Given this list of marker genes Tamm41, Nr1h4, Mvd, Pigc, Isyna1, Adgrf5, Inpp1, Itpkb, Pdgfb, Dpm3, Pip5kl1 (NCBI Gene Id 227733), Cds1, Smg1, Dhrs7b, Acsl5, Pigm, Chpt1, Chkb, Pik3c2b, Slc27a1, Ppard, Pigh, Pcx, Hycc2, Dgkk (NCBI Gene Id 331374), Sgms1, Piga, Inppl1, Pik3cd, Tafazzin (NCBI Gene Id 78810), Uvrag, Lpcat2b, Lpgat1, Fitm2, Agpat3, Pik3ca, Pigz, Atm, Pip4k2a, Ptprq, Hmgcs2, Pip4k2b, Pigf, Abhd5, Sptlc1 (serine palmitoyltransferase, long chain base subunit 1), Ttc7, Agpat2, Fdps, Htr2a, Dgkh, Cept1, Cwh43, Lpcat4, Lpcat3, Lclat1, Hexb, Lpcat1, Dpm1, Pi4ka, Far1, Pi4k2b, Etnk1, Pgap1 (NCBI Gene Id 75976), Abca8b, Cds2, Pign, Pld1 (phospholipase D1), Pip5k1c, Lcat, Pla2g5, Ormdl1, Fabp5, Sphk2, Pisd, Idi1, Gpaa1, Ptdss2, Pigb, Inpp4a, Pigw, Vapa, Pla2g6, Sh3yl1, Rab38, Fitm1, Pik3cb, Pgap3, Pigv, Samd8, Pigq, Dolk, Bpnt2, Sgms2, Itpkc, Gpat4, Hycc1, Flvcr1, Pip5k1a, Mppe1, Chka, Ptdss1 (NCBI Gene Id 19210), Gpat3 (glycerol-3-phosphate acyltransferase 3), Agpat5, Impa2, Cdipt, Pik3r4, Ptpmt1, Mboat7, Apoa1, Mboat2, Pyurf, Bscl2, Pcyt1b, Ip6k1, Etnk2, Pigo, Fabp3, Pgap2, Agpat1, Selenoi (selenoprotein I), Dgkq, Abhd4, Ajuba, Pip4k2c, Idh1, Dgkd, Pigl, Capn2 (NCBI Gene Id 98318), Pik3c3, Cln3, Abca2, Becn1, Gpam, Acsl3, Dhdds, Pdgfa, Erbb4, Serac1, Pnpla3, Crls1, Scp2, Pigu, Plcg2, Dgki, Lpcat2, Pi4k2a, Pcyt2, Itpka, Pigp, Htr2b, Vac14, Alox15, Serinc1 (serine incorporator 1), Slc30a5, Pik3cg (phosphatidylinositol-4,5-bisphosphate 3-kinase catalytic subunit gamma), Abhd8, Plscr1, Pmvk, Idi2, Impa1, Pgap4, Ggps1, Pla2g4a, Dgkb, Nus1, Ttc7b, Hdhd5 (haloacid dehalogenase like hydrolase domain containing 5), Pi4kb, Pla2g4c, Bpnt1, Hmgcs1, Tmem38b, Acsl6, Sptlc2, Pgs1, Pik3c2g, Inpp5e, Chp1, Gpat2, Dgkz, Pigg, Pigx, Pigt, Serinc5, Serinc4, Mvk (NCBI Gene Id 70098), Pik3r1, Pip5k1b, Pigs, Ip6k2, Efr3b (NCBI Gene Id 668212), Abca8a, Tmem150a, Inpp4b, Pemt, Osbp, Pld2 (phospholipase D2), Fgf7, Dpm2, Atg14, Plscr3, Pigyl, Ip6k3, Mboat1, Ormdl3, Agpat4, Dgkg, Fig4 (NCBI Gene Id 103199), Htr2c, Plaat3, Dgke, Pigk, Sh3glb1 (NCBI Gene Id 99782), Pcyt1a, Dgka, Pik3c2a, Apoa2, here is a description of the gene set: The chemical reactions and pathways resulting in the formation of a phospholipid, a lipid containing phosphoric acid as a mono- or diester. studied in species Mus musculus Mouse Gene Set: GOBP_PHOSPHOLIPID_BIOSYNTHETIC_PROCESS